The following is a description of a gene set: Human Gene Set: GNF2_SPI1 Neighborhood of SPI1 spleen focus forming virus (SFFV) proviral integration oncogene spi1 in the GNF2 expression compendium Neighborhood of SPI1 species: Homo sapiens, and this is the list of marker genes: PILRA, IGSF6, APOBEC3A, FRAT2, HCK, CLEC7A, FPR1, NCF2, BACH1, SPI1, TMEM127, AQP9, MNDA, LST1, ARRB2 (arrestin beta 2), UBE2D1, GCA, FRAT1, P2RY13 (purinergic receptor P2Y13), MSRB1, RARA, MYO1F, TLR1, C5AR1, PLXNC1, PPBP, TNFSF10, NADK, LY96, FCGR2A, SECTM1, VASP, FOLR3, CSF3R